Given this list of marker genes NDUFB5, RRP15, CCDC82, SMARCAD1, JRKL, PIK3R1, C10orf88, ENTHD1, IQUB, CCL18, TTI2, RBM7, TAX1BP1, C17orf58, DYRK4, CDKN2AIP (NCBI Gene Id 55602), VPS13C, TOMM70, EDEM3, LINC00867, BAG4, NCBP1, ARFGEF1, PPIL4, LACTB2, THNSL1, H3-3B, PAPPA, ARV1, ORC5, BTG3, PTBP3, AK6, ZNF517, FNBP1, ZNF44, EMC2, SLC35B3, NMD3, EVL, SMU1 (NCBI Gene Id 731253), TCEANC, ANKRA2, CRYBA4, GLRX3, TFAM, HAUS1, DIS3L2, PDS5B, FOXN2, KDM3A, ZFR, NFE2L2, GADD45G, PPHLN1 (NCBI Gene Id 51535), TCAIM, ALCAM, ZNF134, TADA1, SFT2D1, SUGT1, ZNF706, KLHL9, ALG10, ABHD17B, ZNF451, CEP120, H3-5, CUL1, MRPL15, CXXC4, PIAS1, ARL1, MFAP3, ELF2, SPIN4, UFM1, COPS2, LYSMD3, DTWD1, SAR1B, DDX6, P2RY10, SMAD5, LINC01218, GPX7, NOMO2, ELAC1, ELF1, ZBTB1, RBM12B, ZNF347, BLZF1, POT1, IMPACT, ATXN7, ENY2 (ENY2 transcription and export complex 2 subunit), CROT, PAIP1, KLHDC1, CEP170, SEM1, SCAMP1, ZNF804A, LCORL, GINM1, RIMOC1, OGFRL1, IDE, GNAI3, MBNL2, PPIL3, TMEM106B, TRBV4-1, KRIT1, IER3IP1 (immediate early response 3 interacting protein 1), SLC25A24, BAG2, CRLF3, KHDRBS2, VPS45, NR1D2, RAB1A, IQCB1, GTPBP8, KIF3A, CNOT7, SMIM15, SGO2, DCTN6, IPCEF1 (NCBI Gene Id 26034), TEX30 (NCBI Gene Id 93081), THUMPD2 (NCBI Gene Id 80745, THUMP domain containing 2), NBEAP1, PEX3, SAMTOR, GSPT1 (G1 to S phase transition 1), WDR47, RPTOR, PRMT3, COLEC12, TRMT1L (NCBI Gene Id 81627), CD69, EMCN, HSBP1P2, PHF3, AFF4, MICA, C3orf38, SNHG5, SMC2, SLU7, PPP1R2, XRN1, SEPTIN7P7, RASA1, BANK1, ACADSB (acyl-CoA dehydrogenase short/branched chain), SMC6, FRG1, RAC1P4 (NCBI Gene Id 286472), KLF10, RAD51AP1, NSUN6, IFT74, ACTR3C, TNFAIP8, IFT57, ATF7IP, VRK1 (NCBI Gene Id 7443), RB1, PAFAH1B1, CAVIN4, COQ10B, ARHGAP5, ZBTB11, MORF4L2, COQ5, U2SURP (U2 snRNP associated SURP domain containing), ELAPOR2, GPBP1, EEF1AKMT2, IMPA1, RAB2B, TAF12, FBXL13, FUNDC2P2, DCUN1D4, KBTBD2, RNF138, RB1CC1, HEMGN (hemogen), SPRY1, ARHGAP10, RAB3GAP2, TGDS, SLFN14, KLRA1P, RIOK2, KIAA0586, XIAP, SEC22A, STAM2, ABHD18, CCDC25, LSM14B, MTREX, RLIG1, PI4K2B, IL7, GUSBP11, USP15, ZNF33A, RGCC, GABPB1, NMI, TOMM40L, CLK1, APOOL, ATP6V0A2, SGTB, GPATCH2, DCAF16, AASDHPPT, MORC3, ACAP2, PHF6, BIRC3, SPC25, OSBPL3, NPAT, LMBRD2, RCHY1, ANGPT1, C21orf91, ATG2B, SCFD1, COBLL1, LYST, FAR1, FAM76B, PSMD10, DENND4A, TIPRL, CKAP2L, KANSL1L, CREB1, PIP5K1B, UTRN (NCBI Gene Id 7402), DDX3Y, RP9, PLCH1, TANK, INSIG2, AHR, HIBCH, NCBP2, COCH, CHODL-AS1, FAM13A, here is a description of the gene set: from publication Berger JS, Cornwell MG, Xia Y, Muller MA, Smilowitz NR, Newman JD, Schlamp F, Rockman CB, Ruggles KV, Voora D, Hochman JS, Barrett TJ (PMID 39164233) Human Gene Set: BERGER_PLATELET_HYPERREACTIVITY_PRESS_DOWN species: Homo sapiens Genes down-regulated in patients with a hyperreactive platelet phenotype Platelets are key mediators of atherothrombosis, yet, limited tools exist to identify individuals with a hyperreactive platelet phenotype. In this study, we introduce a tool, the Platelet Reactivity ExpreSsion Score (PRESS), which integrates platelet aggregation responses and RNA sequencing. PRESS performs well in identifying a hyperreactive phenotype in patients with PAD (AUC 0.81, 95% CI 0.68 -0.94, n = 84) and in an independent cohort of healthy participants (AUC 0.77, 95% CI 0.75 -0.79, n = 35). Following multivariable adjustment, PAD individuals with a PRESS score above the median are at higher risk for a future cardiovascular event (adjusted HR 1.90, CI 1.07–3.36; p = 0.027, n = 129). Incorporating PRESS into the analytical pipeline, PRESS was enriched in the platelet transcriptome of patients with versus without atherosclerosis. In conclusion, this study derives and validates the ability of PRESS to discriminate platelet hyperreactivity and identify those at increased cardiovascular risk.